The following is a description of a gene set: A proteinaceous scaffold found between homologous chromosomes during meiosis. species: Mus musculus Mouse Gene Set: GOCC_SYNAPTONEMAL_STRUCTURE, and this is the list of marker genes: Xlr5a, Gm21996, Smc1a, Gm28870, Hormad2, Gm28576, Gm2012, Slxl1, Plk1, Rad51, Mlh3, Gm10230, Polb, Kash5, Gm28510, Gm14525, Gm20890, Smc3, Syce2, Sycp3, Brca1, Fkbp6, Gm21095, Gm10488 (predicted gene 10488), Gm21865, Msh4, P3h4, Gm5168, 3830403N18Rik, Msh5, Xlr4b, Rpa1, Gm4297, 4930447C04Rik, Xlr3b (X-linked lymphocyte-regulated 3B), Gm1140, Gm28102, Xlr5c, Gm5935, Rnf212b, Gm20817, Gm7958, Blm, Stag3, Gm28961, Xlr4a, Sycp2, Syn1, Xlr3a, Gm29554, Syce1l, Gm773, Dmc1, Gm1993, Syce3, Slx, Hormad1, Tex12, Gm20736, Sycp2l, Gm29276, Gm6121, Incenp, Syce1, Xlr, Gm5934, Gm5169, Gm20843, Gm20870, Gm28919, Gm20820, Rad21l, 1700013H16Rik, Gm21627, Gm20911, Gm2030, Xlr5b, Gm21117, Sycp1, Gm20824, Gm29866, Smc1b, Rec8, Gm21760, Xlr3c, Gm21858, Gm21294, Brca2, Rnf212, Mei4, Mlh1, Tex11, Hspa2, Xlr4c, Lig3, Ccnb1ip1 (cyclin B1 interacting protein 1)